The following is a description of a gene set: Human Gene Set: GOBP_REGULATION_OF_DEFENSE_RESPONSE Any process that modulates the frequency, rate or extent of a defense response. species: Homo sapiens, and this is the list of marker genes: GRAMD4, AREL1, PPP2R3C, DAB2IP, SLAMF8, CASP8, HGF, IL22, PLSCR1, CARD8, MIR590, TXK, MUL1, CD300A, AOAH, PDCD4, GPATCH3, MIR181A2, RELA, CX3CL1, XRCC5, LILRA2 (NCBI Gene Id 11027), KLRD1, SUSD4, PARP9, LY96, STAT2, POMC, NR1H4, UBQLN1, FCN1, MCPH1, SERPINE1, CCDC92, JAK2, ARRB2 (NCBI Gene Id 409), CTSC, MAPK14, NEK7, STAT5A, GPR17, ADA, MIR128-1, GKN2, EPHB2, CYBA, USP17L2, CACTIN, RORA, ARMH4, PGLYRP1, SNX6, PLA2G7, RAB11FIP2, SCIMP (NCBI Gene Id 388325), IL20, XIAP, MAP3K8, FCGR1A, BPIFB1, PPP2CA, PTGER3, IFI16 (interferon gamma inducible protein 16), SIRPA (NCBI Gene Id 96784), KLRC1, IKBKE, TKFC, SELENOK, GPS2, FOXP1, MIR138-1, CD200R1L, IL10, CCL1, GIT1, USP18, MAP2K6 (NCBI Gene Id 5608), MMRN2, KIR2DL4, NOD1, LAMP1, MIR200C, DNASE1, FANCA, SFN, POLR3F, ARNT, GRN, MIR223, FLOT1, MARK4, PTPRC, ZCCHC3, ERCC6, ERBIN, MIR181C, BANF1, WNT5A, SLC15A2, SHPK, MKRN2, NEAT1, ADORA2B, TSPAN32, TRIM32, TNFAIP6, MIR17, ADAMTS12, PLA2G10, PYHIN1, LATS1, ZDHHC3, LAG3, IL17RA, C2CD4A, ZC3HAV1, WASHC4, MDK, CALHM2 (calcium homeostasis modulator family member 2), HLA-B, NCF1, IL18RAP, MAS1, LRP8, HSPA8, MIR200B, MIR187, CLOCK, HMGB1, PLA2G3, SYK, IFNLR1, EMILIN2, NAGK, IL22RA1, S100A9, MIR145, CCL24, MIR142, FADD, SMPDL3A, AGT, FOXF1, KCNJ8, NECTIN2, IL15, ELMOD2 (NCBI Gene Id 255520), RHBDF2, PTPN1, ZDHHC18, TNIP1, MARCHF5, HTR2A, SPSB3, RBM47, IL33, TRIM41, IL12RB1 (interleukin 12 receptor subunit beta 1), FGL2, COLEC11, MATR3, NCR1, CLNK, GFI1, GIGYF2, WDFY1, DDT, SLC46A2, FCN3, CD200R1, NFKBIZ, TNF, ACOD1, CREB3, ARG2, NFKBIL1 (NCBI Gene Id 4795), VAMP3, GPR108 (NCBI Gene Id 56927), BRD4, NT5E, TLR6, CD300H, MIR302E, TMEM126A, PSMB4, C1QBP, MIR195, MEFV, TRIL, CHUK, MIR3909, C3, PPP1R13L, COLEC12, TRIM38, GPX1, MIR30C2 (NCBI Gene Id 407032), SETD4, N4BP1, LATS2, NLRP13, RASGRP4, SERPINB9, OTUD4, LYPLAL1, TRAF3, USP27X, IDO1, LRRK2 (leucine rich repeat kinase 2), GBA1, DUSP10, HDAC6, MYD88, MIR206, TNFRSF1B, YTHDF3, PRKDC, IL16, HSP90B1, CST7, NPY5R, ABCC1, BST1, PLCG2, STAT3, LSM14A, PSMA1, SLC15A3, PSPC1, NAPEPLD, C1QTNF3, OPTN, TNIP2, LBP, IRF5, CRTAM, NLRP3, GBP3, MIR140, YWHAE, DEFB114, LACC1, DROSHA, PLK2, TRADD, RAET1E, KARS1, LTF, CSNK1A1, AIM2, HLA-A, PTPN6, PELI1, PAK2, TAX1BP1, YES1, IL17RB, KLRC2, APOE, IFNG, KLK7, NLRC4, TRIM5, HPX (hemopexin), FBXL2, SLC19A1, CCR7, ALOX15, NAIP, ZNFX1, SMAD3, DTX3L, TLR10, MIR26A1 (microRNA 26a-1), TICAM2, SLC39A8, COLEC10, SLAMF6, MIR4691, FABP4, VAMP7, ADAR, CD160, AURKB, TRIM31, CNOT7, POLR3D, RAB7B, LETMD1, TNC, SAMHD1, ABHD17A, PUM1, ABHD12, NLRC3, MAPK13, SETD6, FANCD2, AKIRIN2 (NCBI Gene Id 55122), TIFA, IL23A (interleukin 23 subunit alpha), MIR15B, GRP, NONO, TGFB1 (NCBI Gene Id 7040), SPINK5, CASP5, RTN4, VPS35, FFAR2, PLA2G5 (phospholipase A2 group V), MIR21, SIGLEC16, NECTIN4, CCN4, APOBEC3F, AKNA, SERPING1, SOCS5, LILRA4, SARM1, IRF7, ISL1, GGT2P, RAG1, TICAM1, NLRP4, NKG7, LGALS2, TYRO3 (NCBI Gene Id 7301), CYP19A1, ADORA2A, HYAL2, IRAK2, RICTOR, TRIM15, CD226, AP3B1, INS, MAPK3, RHBDD3, CD36, KLRK1, RASGRP1, F2RL1, CCN3, FEM1A, CMA1, MIR144, SIN3A, ARG1, TYROBP, IRF4, PVR, NR5A2, FFAR3 (NCBI Gene Id 2865), PUM2, CD300C, CEBPA, PYCARD, OTULIN, HLA-DRB1, NLRP14, PBK, NOP53, PIK3R1, FUT7 (NCBI Gene Id 2529), TTLL12, CASP12, OAS1, FFAR4, MGLL, NLRP2B, IL4, NLRP1, LRRC19, ANKRD17, TLR9, NR1D2, FCN2, RIPK2, MAPKAPK3, ADORA1, STING1, MNDA, GHSR, TLR4, CREBBP, CPT1A, GNAS, MIR141, INAVA, ECSIT, HSPA1A, NOD2, SCARA3, SPATA2, CASP3, MAPK8, TTBK1, IL1R1, CYLD, TSLP, NR1H2, PPM1B, RIPK1, DNASE1L3, APPL2, SNCA, PDE2A (NCBI Gene Id 5138), AGER, PTPRS, LILRB1, MIR488 (NCBI Gene Id 574441), RNF125, CD14 (CD14 molecule), DAGLB, MIR105-1, DDX41, NAGLU, CAV1, LDLR, PRKCD, TRIM22, PYDC5, SOD1, PCBP2, KCNK6, OAS3, PLA2G2A, NT5C2, METTL3, C2CD4B, PHB2, MIR126, MAP3K7, PYDC1, TIRAP, HSPD1, LYAR, ABHD8, TAC1, CR1, CEACAM1, GRB2, SAA1, CLEC4E, PARP1, TRAF3IP2, CADM1, DUOXA2, NFKBIA, TREX1, MIR766, NMI, ELP6, EXTL3, TRIM56, MIR6869, BCL10, F12, APCS, HLA-G, CLEC7A, ITCH, IL37, KRT1, IL2, LPL, EVPL, IL6ST, MIR92A1, TNFRSF11A, TREML4, DAGLA, RNF170, VSIG4, DHX9, RNF135, PLCG1 (phospholipase C gamma 1), DSG2, IL17F, SHARPIN, SLC15A4, TLR7 (NCBI Gene Id 51284), FGR, METRNL, ETS1, MIR205, SPN, TASL, EMILIN1, PML, RNF115, YTHDF2, PAK3, MIR4286, GPER1, PPARG, NFKB1, CDH5, MIR657 (NCBI Gene Id 724027), IGF1, KLRC3, ATG12, PTPN22, IRF3, IRF1, TRIM21 (NCBI Gene Id 6737), PPARD, KLF4, EREG, SIGLEC10, DRD2, RB1, UACA, IL18, SPI1, GHRL, IL20RB, NLRP5, USP50, PIK3R6, S100A8, ZDHHC5 (NCBI Gene Id 25921), CD274, PGLYRP2, KCNK13, NLRP9, STAT5B, NFE2L1, UCN, CTSS, SEC14L1, CFH, MBL2, MIR19B1, TRAF3IP3, OSMR (NCBI Gene Id 9180), CASP6, MMP12, CD47, NLRX1, CLEC6A, CRH, FCGR2B, PTPN11, TRIM6, DDX39A, TNFRSF1A, MEF2C, CXCL17, CD28, FYN, MAPKBP1, RPS19, SMPDL3B, LRRC14, CXCL6, MIR15A, PTGS2, ILRUN, TMSB4X, CALHM6, MIR199A1, RNF216, DHX58, NFE2L2, CASP4, IL12A, MAPKAPK2, MIR181B1, PTGER4, NUPR1, DUOXA1, MMP26, APPL1 (adaptor protein, phosphotyrosine interacting with PH domain and leucine zipper 1), RIOK3, ZC3H12A, POLR3C, NLRP8, TRAF6, OASL, GBP5, TRIM65, GGT1, TSPAN6, REG3G, PRKCE, APP, BCR, IKBKB, LEP, NLRP7, LGALS9, CD37, PPARA (peroxisome proliferator activated receptor alpha), PJA2, SERPINB4, RNF26, KLKB1, FOSL1, LPCAT3, IL1B, ASH1L, GPRC5B, BCL6B, WFDC1, GATA6, SYT11, ZNRF1, TOMM70, CARD9, RBM14, CD1D, HSP90AA1, EIF2AK4, CD96, PENK, TRIM62, IL12B, IRGM, ADAM8, MAPK7, FXR1, KAT5, APOA1, RNF39, FNDC4, TIFAB, SOCS3, ADIPOQ, IRAK3, SNX4, FPR2, LTA, BIRC3, IL27, PROC, HAVCR2, KIR2DS2, TREM2, MIR19A, RPS6KA3 (ribosomal protein S6 kinase A3), FURIN, ANXA1, EIF2AK2, RSAD2, SEMA7A, TNIP3, AHR, AARS2, ALPK1, MGST2, TRAFD1, CELF1, CGAS, SH2D1B, RNF185, ZBP1, SELE, ZDHHC1, TNFSF4, IL13, MIR708, STAT1, TARBP2 (TARBP2 subunit of RISC loading complex), ZP3, EIF4E2, TLR3, VAMP8 (vesicle associated membrane protein 8), ENPP3, MVK, LGALS1, STK39, BRCC3, XCL1, CAMK2N1, IL21, MIR221, TRIM44, AGTR1, POLR3B, LAMP2, IL6, NLRP2, LRSAM1, LILRA5, CCL3, TRIM25, S100A14, IL22RA2, MIR204, TNFAIP3, TLR2, DDX60, MIR210, ATAT1, NLRC5, CD200, NDFIP1, ZDHHC9, INPP5D, BIRC2, GPR31, ZDHHC4, SMIM30, TRPV4, RNF34, RFTN1, IFI35, ZNRF4, CLEC12B, PIM1, KLK3, MIR222 (NCBI Gene Id 407007), ZMPSTE24, GPR4, SIRT2 (NCBI Gene Id 22933), BECN1, NLRP11, LRCH4, MIR361, CREB3L3, MACIR, SH2D1A, POLR3G, PPP6C, TRAF3IP1, REG3A, HCFC2, IL17A, BTK, PGC, ESR1, GRPR, CCR2 (NCBI Gene Id 90262), ELANE, NR1D1, STAP1, PARK7, NPY, HLA-F, PDPK1, RABGEF1, APOBEC3G, C1QTNF12, PLA2G2D, PIK3CG, DCST1, IRAK1, FOXP3, MMP8, TLR5, TEK, NLRP6, IRAK4, P2RX7, MIR520E, GPSM3, GSDMD, MED1, MAVS, ERAP1, USP38, FCRL3, OGT, ACP5, KLRC4-KLRK1, OSM, EP300, A2M, MIR149, IPO5, S100A12, PTGIS, RAET1G, MIR520B, CCDC134, GBP1, TIGIT, CEP63, SFPQ, HLA-E, CD81, USP29, KLRC4, IFIH1, ALOX5, PQBP1, SCGB1A1, PARP14, SELENOS, RNF31, OTOP1, DHX33, EPG5, HSPA1B, MIR16-1, TBK1, UFD1, CDC37, TRIM45, CLEC12A, PHB1, RNF144A, SPHK1 (NCBI Gene Id 8877), MIR22, YWHAZ, HCK, TRIM3, MIR920, HMGB2, CEBPB, VAMP2, SRC, PTGES, NLRP12, NINJ1, TLR1, NPLOC4, IER3, KLRB1, IFNB1, IL2RA, FLOT2, FAM3A, IL23R, DNAJA3, GBP2, CD300LF, MMP9, VAV1 (NCBI Gene Id 7409), STMP1, CD300E, MFHAS1, MIR31, FCER1G, CPTP, CRK, BCL6, GATA3, SUCNR1, MIR26B, ZDHHC11, PYDC2, UFL1, FAM76B, UNC93B1, HEXIM1, NLRP10, GDI1, ELF4, IL10RA, GSTP1, PRKD1, LGR4, NCR3, IL1RL2, AKT1, AP1G1, USP15, SBNO2, CASP1, AHSG, TNFSF18, BAP1, PAK1, ATG5, CCL5, EDNRB, GGT3P, MIR20A, IL1RL1, TAB1, TAFA3, MIR146A, LYN, NR1H3, PIK3AP1, TRIM11, XRCC6, NPAS2, ACE2, DTX4, TLR8, PSMA6, SBNO1, RIGI, SQSTM1, HERC5, MIRLET7G, TNFAIP8L2, ISG15, MICA, TNFSF11, ZDHHC12, KLK5, CLPB, IFNK, LRFN5, PTPN2, MICB, UBE2K, DDX3X, MMP3, PPT1